The following is a description of a gene set: Mouse Gene Set: MIR_7662_5P Genes predicted to be targets of miRBase v22 microRNA mmu_miR_7662_5p in miRDB v6.0 with MirTarget v4 prediction scores > 80 (high confidence targets). species: Mus musculus from publication Chen Y, Wang X (PMID 31504780), and this is the list of marker genes: Fzd4, Cnksr2, Samd4b, Slc25a21, Kcnv2, Larp1, Csnk1g1, Slc8a1, Ubn1, Tef, Tagln, Mkx, Zhx3, Zfp821, Rgs14, Unc5b, Kremen1, Nck2, Vamp2, Trarg1 (trafficking regulator of GLUT4 (SLC2A4) 1), Zfp764l1, Sestd1, Irgm2, Nkain2, Tspan7, Znrf1, Nptx1, Vipr2, Vtcn1, Galnt6, Usp14, Serpinb10, Pramel21, Reep3, Abraxas2, Sdc3, Ppp2r5d, Tal2, Cxcl16, Rac1, 5031439G07Rik, Casp14, Cyp26b1, Asb8, Sae1, Etv5, Iqsec1, Rfxap, Neu2, Txlna, Pak5, Plekhm3, Jade2, Gpr25, Atf7ip, Zfp568, Dlg2, Polr1f, Nectin1, Sema5b, Gm4847, Sec14l1, Fgf9, Flot1